Given this list of marker genes SLC8B1, IFI44, BRS3, ZFR2, ZDBF2, HAGH, OGFOD2, HROB, TSKS, KIAA0513, MTG2, CPXM2, ST8SIA5, ATP4B, SFI1, LEFTY2, MUS81, MAP6D1, STRIP1, FGF9, CLXN, TMEM117, KCNS1, TSLP, OPALIN, TEAD3, TMEM80, DDX17 (NCBI Gene Id 10521), TRIM11, AAGAB, BCLAF1, ENPP2, ELMOD3, CACNA1A (NCBI Gene Id 773), CTLA4, AKR1C2, GALR2, STX2, EGFR, MEGF11, ELK4, SLC1A6, NAV3, TRIL, DNAJC5B, SLC20A2, DYNC1LI2, RTBDN, NAV1, TTC14, PLEKHH1, MDH1, LONRF2 (LON peptidase N-terminal domain and ring finger 2), EPM2AIP1, TWIST2, TLE2, FAF2, LRRK2, ELOVL1, DLX3, BBS10, STYK1, CDC37L1, EHD4, CERK, C1orf52, EXOC5, MED17 (NCBI Gene Id 9440), PIDD1, CPT1A, ZNF334, NR2F1, FAM241B (NCBI Gene Id 219738), GPATCH4, CYLC2, VARS2, CCDC115, SAMD7, SGPL1, ADIPOQ, ISL1, TEX261, OGT, YWHAH (NCBI Gene Id 7533), SPRING1, BBS2, PEX10, CASP2, HOXC5, SMKR1, ACTL7A (NCBI Gene Id 138761), LMCD1, NHLRC3, RCN3, DDIT3, GRIA2, DNAI1 (NCBI Gene Id 3393), YBX1, NKX6-1, NPHS2, MIXL1, KCNC3, PHF21B, PRKAB1, APOA1, TMEM88B (NCBI Gene Id 643965), SLC16A2, MESD, LRRC45, NEK9, KPTN, TRPM3, MEP1A, P3H4, KCNK16, STAB1, GRIP1, SH3BP2, SCARNA13, LHFPL3, PTPRN2, ZRANB2, MYOF, CCDC40, SYS1, SPINK4, DOCK7, SPACA7, PLCB2, CBX7, MFSD4A, ACVR2B (NCBI Gene Id 93), EPB41L2, CALCR, CYGB, MBLAC2, SLC2A13, MB (myoglobin), TXNIP, ATP6AP1, IRAK1BP1, EIF4B, PHKA2, MFSD5, HSDL1, DANCR, EFNB1, SNHG10, PFN3, TRPC4, NSRP1, EIF3I, BVES, TMED4, EFEMP2, FOXF2, MUC13, DBI, LTO1, XIRP1, TAGLN3, TMEM41A, MFAP3, GNA14, TMED6, MRPL4, GTPBP8, ARL16, RPUSD4, RPS11, WWC2, NF1, RIIAD1, CD300LB, C8G, LNPEP (NCBI Gene Id 4012), DAPL1, MDGA2, TMEM216, RSRP1, TPO, TMEM30A-DT, GDI1, CDC25B, SLC25A1, ODAM, CYP27B1, CRYAB, GRM5, ZNF276, KLF14, BMF, GCNT2, CDK20, HES1, SNHG17, HTR1B, SPTLC2, METTL17, here is a description of the gene set: Human Gene Set: GSE14769_UNSTIM_VS_40MIN_LPS_BMDM_UP The innate immune system is a two-edged sword; it is absolutely required for host defense against infection, but if left uncontrolled can trigger a plethora of inflammatory diseases. Here we used systems biology approaches to predict and validate a gene regulatory network involving a dynamic interplay between the transcription factors NF-κB, C/EBPδ, and ATF3 that controls inflammatory responses. We mathematically modeled transcriptional regulation of Il6 and Cebpd genes and experimentally validated the prediction that the combination of an initiator (NF-κB), an amplifier (C/EBPδ) and an attenuator (ATF3) forms a regulatory circuit that discriminates between transient and persistent Toll-like receptor 4-induced signals. Our results suggest a mechanism that enables the innate immune system to detect the duration of infection and to respond appropriately. Genes up-regulated in comparison of unstimulated macrophage cells versus macrophage cells stimulated with LPS (TLR4 agonist) for 40 min. from publication Litvak V, Ramsey SA, Rust AG, Zak DE, Kennedy KA, Lampano AE, Nykter M, Shmulevich I, Aderem A (PMID 19270711) studied in species Homo sapiens